The following is a description of a gene set: Genes constituting the BRCA1-PCC network of transcripts whose expression positively correlated (Pearson correlation coefficient, PCC >= 0.4) with that of BRCA1 across a compendium of normal tissues. Many cancer-associated genes remain to be identified to clarify the underlying molecular mechanisms of cancer susceptibility and progression. Better understanding is also required of how mutations in cancer genes affect their products in the context of complex cellular networks. Here we have used a network modeling strategy to identify genes potentially associated with higher risk of breast cancer. Starting with four known genes encoding tumor suppressors of breast cancer, we combined gene expression profiling with functional genomic and proteomic (or 'omic') data from various species to generate a network containing genes linked by 866 potential functional associations. This network shows higher connectivity than expected by chance, suggesting that its components function in biologically related pathways. One of the components of the network is HMMR, encoding a centrosome subunit, for which we demonstrate previously unknown functional associations with the breast cancer-associated gene BRCA1. Two case-control studies of incident breast cancer indicate that the HMMR locus is associated with higher risk of breast cancer in humans. Our network modeling strategy should be useful for the discovery of additional cancer-associated genes. Human Gene Set: PUJANA_BRCA1_PCC_NETWORK species: Homo sapiens from publication Pujana MA, Han JD, Starita LM, Stevens KN, Tewari M, Ahn JS, Rennert G, Moreno V, Kirchhoff T, Gold B, Assmann V, Elshamy WM, Rual JF, Levine D, Rozek LS, Gelman RS, Gunsalus KC, Greenberg RA, Sobhian B, Bertin N, Venkatesan K, Ayivi-Guedehoussou N, Solé X, Hernández P, Lázaro C, Nathanson KL, Weber BL, Cusick ME, Hill DE, Offit K, Livingston DM, Gruber SB, Parvin JD, Vidal M (PMID 17922014), and this is the list of marker genes: POT1, EIF3H, DHFR, ZBTB24, ARC, UBE2D2, NPM1, TAF11, RAD51, RCN2, RFC3 (replication factor C subunit 3), RPLP2, ACYP1, CBX3, SP2, CASP2, PTTG1, HNRNPA3, MIEF1, ING3, MATR3, GPN1, LSM14A, TAF5L, SENP3, HAUS3, DGUOK, ENOX2, FBXW4P1, RGS10, DNA2, PSMA3, PSME2, COASY, HDGF, DDX52 (DExD-box helicase 52), TMEM243, LARS2, CENPI, SMC3, TBCA, PUM3 (NCBI Gene Id 9933), RBM34, SIKE1, CCT6A, CSE1L, AATF, ATP1B3, HTRA2, B4GALNT1, MAD2L1, KPNA6, RAD51C, TAF6, GGCT, MDN1, SRP9, BORCS8-MEF2B, NOP2, DNAJC2, EDRF1, C1QBP, SPAG11B, PDCD10, USP19, CCT3, XRCC5, COX6C, SH2D1A, RNASEH1, RMND5A, PTGES3, EFNB1, LSM2, SLC6A7, CAPRIN1, SHH, GYPE, FDPS, PMAIP1, PIK3CG, INHBA, DLEU2, MCM2, NRAS, RABGAP1L, RB1, MAP3K4, SFT2D2, RNASEH2B, PCDHB17P, CYCS, DNMT1, MEA1, SRSF10, LTA (NCBI Gene Id 4049), POP4, RNF2, CHRND, PMS2P3, CDC25C, GEMIN2, LPAR4, SIT1, POLR3D, CXCR4, HOXD10, ME2, POLE, LIG1, MTR, MRPL19, GRAMD4, DPM1, NUP214, RPL24, PHTF2, KCTD20, PTOV1-AS2, PCGF1, DDX27, RASSF8, CSNK2A2, SF3B1, WARS1, AHSA1, EPB41, RPL14, SMARCD1, RBBP8, PTPN1, FCHO1, NCKAP1L, TNPO3, SNAPC5, CHST7, RPL37, HSPA9, UBE2G1, HSPD1, TIPRL, MTIF2, EIF3E, EED, VDAC1, HNF1A, RNF114, CDC16, FAM120A, CCNF, ATXN3, RBMX, BOLA2, RFC2, GRP, BAX, EIF4E2, ALOX12, UBR5, GPR18, IRAK1, LDHA, SYK, SWAP70, KIF21B, EIF3F, COL21A1, SNORA11F, ADAM20, ANP32B, KRT9, POLR3C, SNRPB2, RAN, SMPD4, PCMT1, DCAF7, MTAP, NME2, GTF2H2, NELFA, PRPF31, POU2AF1, ALG8, XPO1, MFAP3, ADSS2, YAF2, SMARCB1, CEBPG, UBE2N, APEX1, POLR2B, TFDP2, IFNA2, NCBP1, BTF3P11, AFG3L2, NMT1, ATP5MF, SNRPG, TOP3B, YME1L1, E2F5, NFATC3, PSIP1, CDV3 (CDV3 homolog), RPL21, PLXDC1, RPIA, DDX19B, ATIC, COX11, HSPA4, ARCN1, SLC7A6, IGF2BP3, EPHA5, TPP2, RFX5, TRIP13, GNL2 (G protein nucleolar 2), PAFAH1B3, ADNP2, PTP4A2 (protein tyrosine phosphatase 4A2), EIF1AX, COX7B, ZNF318 (zinc finger protein 318), BTF3 (NCBI Gene Id 689), IFNAR2, LTK (NCBI Gene Id 4058), SNRPD1, PRPS1 (NCBI Gene Id 8254), RFC4, MSL3, CRHR1, DLD, PPP3CC, SUB1, TMEM106C, UBE2S, TMEM183A, YWHAB, NR2C1, SLC25A46, KIFC1, MRPS27, ACOT13, GNB3, PLIN3, BARD1, PMPCB, PTPN7, FANCI, ZKSCAN4, CDKN2C, RABEP1, DDB2, RTCA, HDAC2, KCNA1, PSMD10, PNMT, MC2R, BRCA1, THOC2, PLCG2, MYB, AFDN-DT, NDUFS6, SLBP, TAOK2, WTAP, PIGF, HDAC1, CCNA2, ARFGEF2, SNRPD2, RPL17, EEF1E1 (NCBI Gene Id 9521), CASP7, STOML2, SEC23IP, KHSRP (KH-type splicing regulatory protein), NCAPD2, TBX6, MRPS31, PSMB7, KIAA0930, TIMM44, PCYT1A, SUCLG2, DAXX, KRT2, HLA-DOA, MAPK11, NCL, RPL19, ZPR1, FAM76A, EIF5AL1, SRSF9, RSC1A1, OXA1L, BAZ1B, POLR2D, RUVBL2, PLCB4, SAC3D1, GDI2, HCRT, ZNF22, RGS6, PAX3, TUBGCP3, CAST (NCBI Gene Id 831), SLC6A6, POLD3 (NCBI Gene Id 10714), URB2, NUP88, ENSG00000240291, H3C11, CSF3, HCCS, CSNK1G2, RNPS1, SUMO2, U2AF2, PSMD9, VARS1, CTAG2, MTA1, ENO1, ZNF250 (zinc finger protein 250), BYSL, CCT7, UPF2, HEXA, ENSA, ARNT, IL12RB1, ATR, TMEM131L, EP400, IGF1R, SDHB, H4C13, RPS20, CEP135, RNASEH2A, EXOSC7, SRSF8, LSM7, GP1BA, PA2G4 (proliferation-associated 2G4), IMP4, ABCE1, LAMTOR5, ATF2, ZNF184, MAN1A2, TAF12, HNRNPA2B1, DNTTIP2, EEF1B2, GNA13, AP3S1, RREB1, EIF3K (NCBI Gene Id 55373), OIP5, ZNF8 (NCBI Gene Id 7554), POU5F1, UBE2M, FNBP4, SMC5, CDKN3, GGH, KRT32, SPAG5, RPP40, GFOD3P, NASP, HTR7, C1D, CENPC, ZZZ3, POU4F1, HTR2A, PPIH, MED1, UCHL3, XPNPEP1, POLE3, GFI1, ENSG00000289047, PKN1, PCCB, YARS1, TRIM24, RNGTT, IDH3B, FOXK2, ARPC4, UBTF, CLASRP, MYC, PTBP1, CIITA, PTMA, TSFM, MTOR, RBL1, KNTC1, NEMP1, THAP12, AGPS, ZNF345, MCM4, PDK1, BRCA2, CCNB2, RPL15, RPL11, RCC1, DLEU1, U2AF1, PLK4, POLR3G, TGDS, MED21, PIAS2, COPS3, RIF1, BMP7, FAM216A, MFAP1, GIT2, NUFIP1, DDX11, GNPAT, RBCK1, SNX15, RIBC2, DOLPP1, NCK1, THOP1, METAP2, GSR, ARIH2, CCT2, OR2F1, UTP20 (NCBI Gene Id 82900), SNRNP200, ZC3H15, KHDRBS2, OR7E12P, STK24 (NCBI Gene Id 8428), NUP42, TOE1, TDG, SRM (spermidine synthase), ILF3, SNRNP40, NFYB, TGM5, MCCC2, MLN, LAMC2, VAMP7, PSMD7 (NCBI Gene Id 5713), APOBEC1, AURKC, CIAPIN1, PMPCA, UBA2 (ubiquitin like modifier activating enzyme 2), TEC, TFAM, CD1A, RRP9, SLC25A5, ZNF266, UBE3C, IFT20, NCBP2, GINS1, IFRD2, PTTG2, ARHGAP11A, PKMYT1, SMARCA5 (NCBI Gene Id 8467), KYAT3, CNBP, ST6GALNAC4, SRSF3, TRAPPC2B, DBF4, CDC14A, PAX4, MED24, MMS19, ZNF131, PAX5, ECD, PSMB2, FADS1, ORC2, EIF2S1, WEE1, CD79A, DNAJC9, ELOC, H3P37, HS2ST1, VBP1, DHX9, CLP1, MIF, CCND3, EIF3B, PDAP1, IRF4, R3HDM1, PCLAF, TRIM14, PPP2R5C, DDX18, MRPL33, RBM42, TOP1, BUB1, EFNA3, NUDT21, TRIM31, ICE1, RPL6, EFCAB11, UBE2L3 (ubiquitin conjugating enzyme E2 L3), CALR, KPNA2, RRM1, CUL2, NEK2, PAXIP1, PIK3CB (NCBI Gene Id 5291), COPB1, ITGA2B, ELAC2, POLR3F, PTPN22, NUP133, IRF5, HRK, ITPKC, MTHFD2, LSM1, INSIG1, OPRL1, ABCC1 (ATP binding cassette subfamily C member 1 (ABCC1 blood group)), NSUN5P1, SMAD2, RAD21, WASHC5, PRPF40A, EIF3I, TMEM123, PTBP3, MTREX, MYL1, SMC4, P2RY11, CCL3, PPP1CC, MOB1A, BZW1, RNF126, PSMG1, RPS25, CEP162, LYPLA1, TFAP4, MGAT2, HINT1, DCK, PIGC, PUDP, FRG1, SREK1, AK2, MPHOSPH6, HMGA1, PPIG, MDM4, NR1I2, TOP2A, LSM4, TXNL4A, MS4A1, CDT1, NONO, DDX39B, CUL9, ADSL, ZNF134, ITGB3BP, ANP32E, HMGB3, XRCC3, UBE2I, B3GNTL1, TOP2B, EIF2S3, ABO, DOCK2, ESPL1, DDX46, UCP2, RAB30, ZBTB33, AOC2, IMMT, GLE1, TNF, STARD7, BTK, HPRT1, ECE2, CKAP5, SSBP2, DDX39A, CHAF1B, PSMC2, TREX2, ACLY (ATP citrate lyase), R3HCC1L, RB1CC1, TNFRSF17, BLMH, FUBP1, MAPKAPK5, RPS5, ZCCHC14 (NCBI Gene Id 84995), PWP2, KRT20, STAT5A, GLIPR1, PFDN6, ZNF24, RPL18A, ATP5PB, SSR1, BPI, FANCC, FBL, TRAF4, NAP1L1, PRPSAP2, ITPK1, NFX1, TSNAX, ZNF101, PPEF2, EXOSC8, SUPV3L1, MBD4, TBL3, OXSR1, POU6F1, ERH, SPATA31A7, RBBP4, RBBP5, TATDN2, GSTT4, CCNB1, RPS19, RAC2, EIF1AY, DUT, PARP2, NAP1L4, GTF2A2 (NCBI Gene Id 2958), IKZF1, CNTRL, IARS1, ADK, DIAPH1, KIF23, INTS10, JRK, MTDH, IMPA1, ARPC2, JARID2, RPL23, PRPF4, WAPL, PHF20, RAE1, IL4, ZWINT, SEM1, NHP2, MTERF1, CHAF1A, RAP1B, ETF1, PVR, SRSF1, CUL1, POLE2, UBFD1, TRIM28, TIMM8A, SIM2, PRPS2, NOX1, SET, ZNF195, DNASE1L1 (deoxyribonuclease 1 like 1), PPIL6, CCNG1, NAE1, BTAF1, NBN, TLK2, ANAPC10, CBX5, PIBF1, CCNT2, E2F3, TCF20, STRN, EIF5B, RBM3, INVS (inversin), HPS1, CDC23, MRPL23, PARP1, SLC7A1, RALGAPB, PRP4K, LINC02172 (long intergenic non-protein coding RNA 2172), SEMA3D, TCOF1, PES1, MDM2, AURKB, PSMA4, LMNB1, UTP18, SNRPB, ISG20L2, FGF18, TIAL1 (NCBI Gene Id 8430), SEC61G, ERAL1 (NCBI Gene Id 26284), RRP7A, GNAT1, MCM3, CDC25A, SP100, CAPZA1, FH, SEPTIN6, GRIP2, HMGCR, PCNA, NAT1, CDK13, SART3, OSBPL3, RNF6, KIF20B, COPS5, PHB2, YIPF4 (NCBI Gene Id 84272), RBBP6, UQCRH, MRPS18B, GTF2H1, ATP5MJ, WAS, DIDO1, ZC3H4, PAK2, STX2, AIMP1, SRSF11, PCDHA12, EIF3M, RPL36A, TUBA1B, UBAP2L, HMGN4, EIF2B5, MTNR1B, EIF4A3, PFKFB2, RXYLT1, TAF5, SH2B2, IFFO1, SQLE, PRMT3, SLC19A1, CREBZF, MAZ, DKC1, LARP4, SNRPA, ERCC3, NCAPH, DTYMK, CYP51A1, TAF2, NPIPB15, PTDSS1, CNOT9, CDC27 (cell division cycle 27), MEN1, SAFB, VAMP1, SRP19, H4C3, AP1G2, MKI67, CD27, API5, AIFM1, PPIA, RSAD2, TKT, SELENOF, ADNP, MTX2, KIF2A, TMPO, DCP2, GCSH, CYP2C18, PDS5A, KATNB1, GLMN, CCNE1, CD180, H2AZ1, GAPDH, MR1, PSMA5, LIG3, G3BP1, C6orf62, IL2RG, NSA2, TFRC, NKRF (NFKB repressing factor), DDX10, TM9SF4, TBPL1, POM121, TTF2, CDK1, SPC25, PSMD14, PRPF19, RANBP1, YWHAE, UNG, FBLN1, CD47, PAX2, PABPC4, ESR2, TAF4B, ERC2-IT1, MARS1, NECTIN1, PLAGL2, ACKR2, EIF4H, CLPX, PPP1R8, SSBP1 (single stranded DNA binding protein 1), PRRC2C, EIF3D, CENPF, RPL13A, ASH2L, TTTY2, AHCY, CCNE2, ZNF207, PSMB1, XRCC6, RPL27, CARM1, ANKRD26, ACVR2B, COX5A, ABCF2, POLA1, WDR77, UFD1, FUT4, RRS1, CD1C, KXD1, RECK, IGHM, CEBPZ, NUP160, RFX4, HSPH1, DAP3, PPM1A, HNRNPM, DDX49, IFNAR1, PIK3CD, UQCRC2, ATG12, PFAS, CTPS1, ZNHIT3, SCFD1, RGS13, CBFB, ERP29, CDC6, DEK, PFDN4, GPR3, CDK5R2, CCT5, IARS2, ELF1, PPM1G, STMN1, PARN, NUP50, SNAPC1, GPR37L1, HNRNPC, NUP210, YBX1P5, IQCB1, JCHAIN (joining chain of multimeric IgA and IgM), BCAT1, NACA (NCBI Gene Id 4666), GTF2E2, BCL2L11 (BCL2 like 11), YY1 (YY1 transcription factor), LDHB, MAPRE1, GPR15, ARHGDIB, UBE2D3, CENPE, ABCB7, CDC45, HNRNPL, POLD2, DNAJC24, RPL5 (ribosomal protein L5), DHX16, MRPL58, ORC1, RPS15A, MCM5, CRLF3, NGDN, SMARCD2, BUD31, CD40, ERI2, BRAP, DLAT, LIAS, TOMM34, POLB, VRK1, MS4A2 (NCBI Gene Id 3477), MBD2, IGHV5-51, SLC15A1, NXPH2, POLR1C, EPM2A, PDCD2, BLNK, NDC80, BCAS2, MICB, KYNU, SEC61B, PSMC3IP, USP1, TCEA1 (transcription elongation factor A1), TTI1, ADAM22, TIMM17A, OARD1, STAG2, BLM, GRB2, MAX, PIGB, UBE2C, ANAPC5, SYNCRIP, BAZ1A, SLC16A6, ATP6V1H, ZNF804A, CKS1B, RGS19, CD2AP, TBCE, CD96, KIF14, TIMELESS, NOP14, E2F1, ILF2, CREG1, ZMPSTE24, GTSE1, ZC3HAV1, KRAS, TAF4, EXOSC10, RPL27A, COL19A1, EEF1G, COX7A2L, MPHOSPH9, CPSF4, RPL30, PRDX3, COL10A1, PGAP2, TTK, DGKE, TBX1, NUP62, RELB, FABP5, ACTR2, KLHL18, RABGGTB, SRRM1, NSL1, CHERP, SNRPA1, LAIR2, MCM6, GPLD1, BAG1, SFPQ, UVRAG, RAD51AP1, RPS6, SMN1, CENPS, HMGN3, IRAG2, CDH8, LSM5, EIF2S2, RPL35, PFKFB3, MYCBP, NNT, XCL1, ADA, TRAPPC6A, COX17, IGLL1, LARP7, P2RX3, SNRPC, PLK1, B3GALT5, GEMIN4 (NCBI Gene Id 50628), CDK2, NDUFV2, SLC16A5, KCNA6, HIRA, HDAC3, IFI16, GRK6, RPS6KB2, SNRPE, CCT8, ABI1, FUS, MVK, XPC, KIF2C, TROAP, AP1G1, CEP43, RPS3A, KHDC4, CDK4, GSPT1, RPLP0, SSB, MFNG, HNRNPF, P2RY10, RPS6KB1, MLANA, RPA3, MELK, LCP1, ACTL6A, IGBP1, SLC1A4, CENPA, MYOD1, PLEK, LINC00588, DDX21, GSS, IRF2, ASTN2, RARS1, SRPK1, EWSR1, COMP, MRPL3, TXNL1, ANP32A, EIF5, ACADM, ZNF273, HMGN2, EZH2, GMPS, SRP72, CDC7, RSL1D1, KHDRBS1, HLTF, PDHB, SLC14A2, SSRP1, PPIL2, CTCF, GOSR1, INTS9, GARS1, BET1 (Bet1 golgi vesicular membrane trafficking protein), METTL13, RWDD3, MLLT10, RPL12, TBX5, STK17B, AP3B1, CDX2, ANXA13, MAP4K1 (mitogen-activated protein kinase kinase kinase kinase 1), AURKA, ORC3, ALDH5A1, SFI1, WNT11, UBE2E1, FTSJ1, EYA4, PDE1C, HSPA8, GRIK1, CHEK2, ATXN10, E2F4, GART, USP10, HMGB1P8, DR1, TACR3, PABPN1, GALNT1, SHMT2, BFSP1, ATP13A3, RPL10A (NCBI Gene Id 4736), RRP1B, NDUFS1, DESI2, TCP1, TARBP1, RPS17, RAB3GAP2, NAA10, EEF2, UCK2, TCL1A, IPO7 (importin 7), RAB28, CUL4A, KRT31, RECQL4, GALNT2, DARS1, GJB5, ITFG2, HNRNPU, MSH2, ARPC3, MRPL12, EIF4A1, HNRNPAB, ST3GAL2, ODC1, POLA2, BCL7B, TBC1D31, PRKDC, TK1, ATP5PO, IMPDH2, SMARCA4, XPOT, DBI, CHUK, NUP93, PSMC4, HMGB2, ERCC6, VHL, LRRC42, MAK16, ATP6V0A2, PDS5B, TPR, FGF8, WDHD1 (WD repeat and HMG-box DNA binding protein 1), CPT1A, TCF3, TRIAP1, ATAD2B, SPIB, RIMS1, PSMB8, ZNF337, CTR9, MNAT1, MSH6, RANBP9, EXO1, GPD2, RECQL, NRL, ZBED4, ABRAXAS2, NOLC1, PIM2, NUP155, BNIP2, CA7, GLRA3, IDO1, ARHGEF1, ATP5F1A, AIMP2, KCNB1, GTPBP1 (GTP binding protein 1), KIF11, LSM3, SIM1, CASP3, CYP1A1, SMC1A, MAGEA4, YBX1, UBE2J1, SF3B4, VAV1, DPH2, PCBP1 (NCBI Gene Id 5093), CRCP, RPS23, VENTX, GRM1, NOC2L, LSM6, LBR, PAICS, SUMO1, PRIM1, CD38, ABCG2, CCNH, RPL22, ZNF157, NOP16, MAPK8, CCNC, PSME4, TARS1, SRRT, PARG, NPM3, RUVBL1, ADAM17, TAF9, MDM1, ATXN2L, CKS2, BRAF, PABPC1, MBNL1, PSMA1, ALX3, RPL9P7 (ribosomal protein L9 pseudogene 7), MSH5, MACROH2A1, POLG, TBC1D1, ADAM19, WDR43, ELAVL1, PROP1, BFSP2, REL, RNFT2, KCNN3, MAT2A, PRMT1, SNX4, GTF3C2, DIMT1, PSMB4, TMSB4Y, TTC39A, PTPN2, WRN, EDEM1, MFN1, POLR2J, NSD2, SAP30, M6PR, NPHP1, RBBP7, CNIH1, TYMS, HNRNPK, PSMA2, ALKBH1, CCL23, IKBKE, RAD1, RPL7, ETFA, ZNF330, MAGOH, SLC1A5, IDI1, NUDT1, NUP153, RASA3, SPTB, RPS27A, SNRPD3, MYO1A, FARSA, SNRPF, TARDBP, SMARCC1, ORC5, ATP11B, PNN, NXT2, HNRNPUL1, PDHA1, WFDC8 (NCBI Gene Id 90199), CD22, PSMA6, CNOT3, DLST, MAGEA1, USP13, SF3A3, RCOR1, CDK7, GCFC2, TGFB1, SMNDC1, RPA2, ACTR3, COA1, RPL4, P4HA1, USP34, IFT25, NPAS1, RHOH, ASF1A, PDE6A, NOP56, ITGA4, CNOT1, CLINT1, MED6, LIN7A, LARP4B, CADM3-AS1, RFC5, BOP1, MCM7, DDX19A, KLRC4, PELP1, HNRNPR, CD79B, HMMR, IRF8, RRM2, MPHOSPH10, FEN1, BLK, BNIP1, PAFAH1B2, UTP3 (NCBI Gene Id 57050), DNAJC7, HSP90AA1, ATM, NME1, PYCR1, TRAV9-2, RPA1, TRA2B, CYB5B, GTF2E1, PRKRA, MMP20, MASP2, PART1, PSMC6, THAP9-AS1, IGHV5-78, H2AX, SMC2, DLGAP5, TOR1A, CAD, FXN, ELOVL5, SEL1L3, PRDX1, PNO1, FLT1, STIL, HK2, TXN, OGG1, CHEK1, CD37, TEX30, KPNB1, BCL7A, HNRNPD, GTF2H3, BUB3, ZNF37A, PHOX2B, CEP68, TGIF2, TNK1, FAS, GTF2A1, EBNA1BP2, FGF6, OAS2, CCT4, ST20, GTF3A, SF1, SIGLEC7, HSPE1, CSTF3, MED20, TFDP1, HTR3A, GTF2B, SNW1, HNRNPA1, RPL31, PPP2R1B (NCBI Gene Id 5519), ATP5PF, AIM2, SMG7, LPXN, DMAC2L, GTF2H4, KARS1, MTF2 (NCBI Gene Id 22823), INE1, TPX2, INPP5E, HMGN1, TOMM40, VDAC2 (NCBI Gene Id 7417), PDE12, GIP, SLC7A5, HMGXB4, DUSP11, ZNF202, PSMD3, EIF4B, CSNK2A1, CEP57, RPL36AL, FOXM1, GTF2F2, NDUFB3, NBR2 (neighbor of BRCA1 lncRNA 2), H2AZ2, NUTF2, PMM2, POLR2G, RPL23A, ATF4, MYBL2, TMED5, EEF1A1, CDK11B, ZNF43, CHD4, CETN3, HSF2, ORAI2, ARHGAP19, PPM1D, SRSF2, CBFA2T3, HNRNPH1, ANKLE2, KATNA1, TP53, TMX1, TELO2, RASSF1, ADAM10, MRE11, RFTN1, SLC10A2, RUNX1, SLC20A1, SREK1IP1, KMT2C, NFATC2IP, HDDC2, RPS24, DHX15, MAGEA9, TNFAIP8, CDC20, PWP1, TRAP1, KYAT1, CDC123, PARP3, PGK1, AZIN1, EPRS1, CORO1A, SLC16A1 (solute carrier family 16 member 1), CD19, POLR2H, ACAT2, LY86, TCERG1, HAT1, NUP205, BMS1 (BMS1 ribosome biogenesis factor), GALNS, TOPBP1, POP5, CACNA1E, PPP1R2, TSR1, CNOT8, XRCC2, RAD54L, NSMAF, PMS1, RPS7, RAD17, PPP2R5E, PITPNB, BUB1B, PPP6R1, NOS2, RALY, AFF2, UBE2K, PPP6C, PTEN, FDFT1, TRIM27, LMNB2, SUZ12, NUP188, METAP1, GAPDHS, EXOG, CLNS1A, NUS1P3, TBP, PLCG1, IPO5, TRA2A, ASNS, SERBP1, PEX5